Given this list of marker genes CDK4, CEACAM6, GUCY2C, CLMP, IVNS1ABP, LMOD1, PRDM12, ANO1, KIF26A, EDNRA, GUCY1A1, TP53, SOX10, PHOX2B, RRM2B, IARS2, MDM2, CDKN2A, FUS, ATP1A2, RRM1, SLC26A9, GSTM3 (NCBI Gene Id 2947), DHCR7, CAVIN1, TRAPPC11, NUTM2B-AS1, MT-ND4, LIG3, CPOX, CLCA4, KCNN4, MIF, MT-CO3, STAT3, FLNA, STX1A, PPOX (NCBI Gene Id 7440), HMBS, MYLK, HSD17B10, MT-TQ, HFE, MT-TF, TWNK, FAH, MT-TW (mitochondrially encoded tRNA-Trp (UGA/G)), SLC9A3, COL4A5, ERBB3, MT-CO2, SGO1, TANGO2, ARPC5, DDIT3, FCGR2A, CFTR, PALB2, TXN2, UNC45A, SLC6A14, GLA, MTRFR (mitochondrial translation release factor in rescue), SLC1A3, FOXP3, AAAS, CEACAM3, SAMD9, SON, PALLD, MPV17, GMPPA, SLC6A8, CACNA1A, POLG, MT-TS2, TYMP, IDS, WT1, SMAD4, HNRNPK, ACTB, KRAS, MEIS2, UBR7, CAMK2A, BRCA2, GCLC, DCTN4 (dynactin subunit 4), ACTG2, MYO1H, FLVCR1, MT-TL1, MYH11, SLC18A3, SLC11A1, ZMYM3, RAD21, MT-ND5 (NCBI Gene Id 4540), SMO, RABL3, MRAP, ATP1A3, BRCA1, MT-ND1, MT-TH, MT-CO1, EWSR1, SERPINA1, MT-ND6 (NCBI Gene Id 4541), WFS1, ACTA2, HMGA2, COL4A6, TGFB1, HMOX1 (heme oxygenase 1), CAMK2B, MYL9, here is a description of the gene set: Human Gene Set: HP_ABNORMAL_GASTROINTESTINAL_MOTILITY Abnormal gastrointestinal motility species: Homo sapiens An anomaly of the muscular contractions that propel food though the gastrointestinal tract.